Given this list of marker genes Brca2, Brcc3, Brca1, Nbn, Ppp4c, H2ax, Ppp4r2, H2bc13, Pias4, H4c9, Ercc1, H2bc1, Pcna, H2bc11, Lig1, H4c2, Rps27a, Rpa1, Pole2, Pold4, H4c4 (NCBI Gene Id 319156), H2bc27, Pold1, Pold2, H4c1, Babam1, Ubb, Gen1, Xrcc3, Bard1, H2bc15, Trp53bp1, Pole, H4c6 (H4 clustered histone 6), Rnf168, Firrm, Rfc1, Rad1, H4c12, Rad51b, Rad51c, Slx4, Fignl1, Dna2, Rfc3, H2bc7, Top3a, Polk, H4c14, H2bc22, Mre11a, Rad51ap1, H2bc8 (H2B clustered histone 8), Mdc1, Blm, H2bc12, Slx1b, Hus1, Wrn, H4c3, Mus81, Ccna1, H4c11, H2bc3, Rad9a, Rbbp8, Palb2, Rnf4, H4c17, Kat5 (NCBI Gene Id 81601), H4c18, H2bc9, H4c8, Ube2n, Rad52, Ercc4, Polh, here is a description of the gene set: part of: Homology Directed Repair electronically inferred by orthology from the curated human pathway studied in species Mus musculus This event has been computationally inferred from an event that has been demonstrated in another species.<p>The inference is based on the homology mapping from PANTHER. Briefly, reactions for which all involved PhysicalEntities (in input, output and catalyst) have a mapped orthologue/paralogue (for complexes at least 75% of components must have a mapping) are inferred to the other species. Reactome Pathway: HDR through Homologous Recombination (HRR) or Single Strand Annealing (SSA)